The following is a description of a gene set: studied in species Homo sapiens Human Gene Set: WP_CIRCADIAN_RHYTHM_GENES Circadian rhythm genes, and this is the list of marker genes: ATF4, PPARA, PRKG2, SIX3, SFPQ, NAGLU, HEBP1 (heme binding protein 1), NR2F6, JUN, NOCT, NPY2R (NCBI Gene Id 4887), TIMELESS, NR1D1 (nuclear receptor subfamily 1 group D member 1), RORA, CIART, ID4, DHX9, SETX, TPH2, CRY1, SIRT1, TOP2A, SERPINE1, LEP, TH, USP2 (NCBI Gene Id 9099), NOS2, EGR3, EGR1, LGR4, PSPC1, DRD2, NCOA2, SLC6A4, TYMS, ID3, NTRK3, CIPC, AHCY, PRKAA2, PML, BHLHE41, HNF1B, HDAC2, MAGEL2, NPAS2, ADORA2A, CRTC1, PROK1, UTS2R, SUV39H2, ARNT, BHLHE40, KCNMA1, ATOH7, SIN3A, DYRK1A, ID2, MAPK10 (NCBI Gene Id 5602), MTA1 (metastasis associated 1), TNFRSF11A, NCOR1, DRD3, PER2, NMS, AANAT, CHRM1, NAMPT, OPN3, MAPK8, STAR, CSNK1D, RELB (NCBI Gene Id 5971), PROK2, PPARG, PPARGC1A, SLC9A3, TOP1, SOX14, ATF5, GHRL, MTNR1B, HTR7, EP300, NPS, TPH1, RAI1, MC3R, HCRTR1, CRY2, THRAP3, NGFR, NR1H3, CAVIN3, HNRNPD (heterogeneous nuclear ribonucleoprotein D), F7, EZH2, GNAQ, MYBBP1A, DRD1, PER3, HDAC1, HDAC3, PAX4, KDM5A, PASD1, CPT1A, NONO, PROX1, ZFHX3, AVP, CSNK1E, JUND, PRKAA1, BTBD9, KMT2A, GFPT1, UTS2, ADORA1, NLGN1, HNRNPU, AGRP, NFIL3, CCAR2, RORC, DBP, KLF10, DRD4, SFTPC, PPP1CB, DDC, CLDN4, ADCY1, METTL3, BMAL1, ROCK2, PRKDC, MTTP, RBM4B, CST3, CUL1, ADA, CRX, PPP1CA, UBE3A, RBM4, GHRH, ARNT2, FBXL3, GNA11, RPS27A, AHR, CLOCK, OPRL1, FAS, PHLPP1, RORB, PROKR1, SIK1, SREBF1, MTNR1A, CHRNB2, OGT, CRH, GSK3B, KLF9, HS3ST2, PTEN, UBC, MAPK9, HOMER1, PRKCG, NR1D2 (NCBI Gene Id 9975), OPN4, IL6, NRIP1, PRF1, UBA52, CREB1, CARTPT, DDX5, TP53, FBXW11, BTRC, NKX2-1, PRMT5, PPP1CC, MAGED1, HCRTR2, ADIPOQ, KCND2, PTGDS, PROKR2 (prokineticin receptor 2), KCNH7 (potassium voltage-gated channel subfamily H member 7), NTRK1, SUV39H1, CREM, PER1, SKP1, BMAL2, CDK4